Given this list of marker genes SERINC1, SHC1, CENPV, CLEC5A, BTG3, STARD5, CITED2, SYNPO2, SOCS3, HSD17B13, SBDS, FN1, IFT81, TOR1AIP2 (NCBI Gene Id 64163), OSGIN2, LONP2, STXBP1, ADCY3, CPLX2, FLT1, TFEC, ZP2, DENND2B, POLR1B, CTNND1, SLFN12L, INTS8, CCNA2, IL1RN, PPP2R3A, MGAT4C, TULP4, MAPK6, SPTLC1, ANKRD2, FBXW8, SEMA6B, TRMT10A, TNFRSF8, MYNN, DTWD1, NDUFB2, PACRG, TNFRSF1B, NDUFAF7, AP3M1, MDFIC, MT2A, PAFAH1B1, INO80C, IFNB1, RAD18, YME1L1, PLSCR1, SLAMF1, RNF19A, SC5D, SPRYD7, RAB17, ESRRG, NRG4, ENDOD1, TM9SF3, LMO4, GAL3ST1, IGDCC3, KBTBD2, CASP4, HAL, SAMSN1, FOXF2, IER5, SYNE2, DLD, DHX32, HLA-C, ZDHHC14, AADAT, HSPA1B, DUSP16, SSBP3, POLA2, ANXA9, WNT16, CD96, MTMR14, CLINT1, PRICKLE3, GOLGA7 (golgin A7), MAFF, ETF1, IKBKB, UCHL5, MARCO, PTPRE, CSF3R, KATNBL1, PFKP, EIF2AK4, LGI4, GNAT2, IL23A, BAAT, RBM7, DPF2 (NCBI Gene Id 5977), WASF2, PCNX1 (pecanex 1), TAF7, PPP1R2P1, LLGL2, PRRC2A, CD70, PLG, MUC13, CCNL1, MARCKSL1, GSDME, AK2, FAM174B, FAM184B, SALL4, SNAP23, OLFML3, USP15, NUMB, TMEM120B, NTAN1, PHLDB1, CPQ, ADK, MTMR7, HOOK2, TMA16, TAMALIN, KIF1A, STXBP3, CLCF1, FURIN, B3GAT1, ABI1, SIMC1, GOLPH3, ELMO2, PDLIM1, TMEM94, TJAP1, RASAL2, SRP54, SH3TC1, PDE4B, TRPM6, SLCO1C1, SRF, KLK4, PRXL2C, CST11, BCAM, MYLIP, SMC5, CNOT9, RALGDS, BCL2L11, CLIC3, MEF2A, AGXT, NUP93, ASB15, TMED7, SIX1, NDEL1, EHD1, SAPCD1, CATSPER1, NTHL1, BMP5, SMAD2, THRSP, SEMA3C, ALPK2, STAU1, FRMD6, RAB32, PLEKHA3, BNIP2, MMADHC, GNA13, TBL3, KLHL25, NCOA2, ZFAND2A, ITGB6, CAV1, IGSF6, ARG2, KHDC4, PPME1, SECISBP2L (SECIS binding protein 2 like), RPS6KA2, PSMD3, ETS2, here is a description of the gene set: Human Gene Set: GSE17721_CTRL_VS_GARDIQUIMOD_2H_BMDC_DN mouse primary BMDCs were stimulated with tlr ligands and gene expression changes were profiled on Affymetrix arrays from publication Amit I, Garber M, Chevrier N, Leite AP, Donner Y, Eisenhaure T, Guttman M, Grenier JK, Li W, Zuk O, Schubert LA, Birditt B, Shay T, Goren A, Zhang X, Smith Z, Deering R, McDonald RC, Cabili M, Bernstein BE, Rinn JL, Meissner A, Root DE, Hacohen N, Regev A (PMID 19729616) species: Homo sapiens Genes down-regulated in comparison of control dendritic cells (DC) at 2 h versus those stimulated with Gardiquimod (TLR7 agonist) at 2 h.